The following is a description of a gene set: Human Gene Set: chrXq22 species: Homo sapiens, and this is the list of marker genes: MTND6P32 (NCBI Gene Id 107075200), GLA, TSPAN6, TSC22D3, ENSG00000303214 (NCBI Gene Id 124905205), TCEAL5, GPRASP1, TEX101P1, GPRASP2, TEX13B, PPIAP89, TCP11X2 (t-complex 11 family, X-linked 2), ARMCX2, TBC1D8B, MYCLP1, LL0XNC01-250H12.3, NXF3, ARMCX7P, SYTL4, SRPX2, RAB40AL, NLRP3P1, XRCC6P5, MID2, TCEAL2, RNU6-587P, RADX, FOXN3P1, PWWP3B, RBM41, PCDH19, ZMAT1, MTCO3P19, VSIG1, BTK, H2BP8, GLRA4, SLC25A53P1, TMSB15A, MORF4L2, MTATP6P19 (NCBI Gene Id 107075275), NSA2P3, MORC4, CSTF2, TCEAL1, PRKCIP1, RNU6-207P, ARMCX5-GPRASP2, TCEAL3, RAB9B, MTND2P2, NRK, TMEM230P1 (TMEM230 pseudogene 1), TCEAL3-AS1, PRPS1, TNMD, PHB1P10, ARL13A, RPL36A, COL4A6, TMSB15C, TCEAL4, TEX13A, ARMCX6, ATG4A, RNU6-589P, H3P45, NANOGNBP3, RNU6-309P, PLP1, C3orf49P1, NAP1L4P2 (nucleosome assembly protein 1 like 4 pseudogene 2), BEND7P1, RPL21P132, MTCO2P19, BEX2, NUP62CL (nucleoporin 62 C-terminal like), TCEAL8, ENSG00000236064, NXF5, XKRX, IRS4-AS1, DRP2, COL4A5, GK4P, TCEAL7, CNEP1R1P1, CENPI, IL1RAPL2, MTCYBP32, ARMCX5, DPPA3P1, RNU6-30P, RAB40A, ENSG00000286794, DNAJA1P3, RNF128, EEF1A1P40, FRMPD3, SERPINA7, NXF2B, MTND1P32, BEX4, MTCO1P19, ARMCX3-AS1 (NCBI Gene Id 100128574), ESX1, SLC25A53, TCP11X1, MTND4P32, ZCCHC18, TAF7L, FRMPD3-AS1, ENSG00000202231, TMSB15B, RPL36A-HNRNPH2, TRMT2B-AS1, CTDSPL2P2, H2BW2, H2BW1, LINC00630, MIR548AN, CLDN2, H2BW3P, NXF4, TIMM8A, CTDSPL2P1, DNAAF6 (dynein axonemal assembly factor 6), NOX1, ARMCX1, ARMCX4, BEX1, HNRNPA1P26, KCTD9P2, ELF2P1, GPRASP3, RPL18AP14, ARMCX3, RPSAP59, MTND6P13, NCBP2L, TCEAL6, IRS4, MORF4L2-AS1, GAPDHP77, CSGALNACT2P1, NUDT19P2, BEX5, MTND5P26, HNRNPH2, RNU6-345P, RIPPLY1, SERPINA7P1, GTF3C6P2, H2BP9, RPSAP8, RAD21P1, KRT18P49, HNRNPA1P27, CSGALNACT2P2, TMEM31, FAM199X, TMSB15B-AS1, NXF2, YWHAQP8, RNA5SP511, PSMD10, TRMT2B, PPIAP90, TCEAL9, RNU6-934P, BEX3, B3GNT2P1 (NCBI Gene Id 100422469), TCP11X3P, TMEM35A